The following is a description of a gene set: studied in species Homo sapiens Reactome Pathway: RUNX1 regulates transcription of genes involved in differentiation of keratinocytes The RUNX1:CBFB complex directly inhibits transcription of the SERPINB13 gene, a gene involved in keratinocyte differentiation that is frequently down-regulated in head and neck cancers. RUNX1 also inhibits transcription of STAT3 inhibitors SOCS3 and SOCS4, resulting in elevated STAT3 activity. RUNX1-mediated increase in STAT3 activity, first discovered in keratinocytes, is thought to be involved in the maintenance of epithelial stem cells and contributes to development of epithelial cancers, including squamous cell carcinoma (SCC) of the skin. part of: Transcriptional regulation by RUNX1, and this is the list of marker genes: CTSV, CTSL, SOCS3, SOCS4, CBFB, SERPINB13, CTSK, RUNX1